The following is a description of a gene set: This event has been computationally inferred from an event that has been demonstrated in another species.<p>The inference is based on the homology mapping from PANTHER. Briefly, reactions for which all involved PhysicalEntities (in input, output and catalyst) have a mapped orthologue/paralogue (for complexes at least 75% of components must have a mapping) are inferred to the other species. Reactome Pathway: Orexin and neuropeptides FF and QRFP bind to their respective receptors species: Mus musculus electronically inferred by orthology from the curated human pathway part of: Peptide ligand-binding receptors, and this is the list of marker genes: Hcrtr1, Npff, Qrfp, Hcrt, Hcrtr2, Qrfprl, Npffr1